Given this list of marker genes Chil4, Chi3l1 (NCBI Gene Id 98675), Ctbs, Ovgp1, Chia1, Chit1, Chil3, Chid1, Fibcd1, here is a description of the gene set: studied in species Mus musculus Mouse Gene Set: GOMF_CHITIN_BINDING Binding to chitin, a linear polysaccharide consisting of beta-(1->4)-linked N-acetyl-D-glucosamine residues.